Given this list of marker genes SLC7A5, SLC32A1, SLC1A2, SLC36A4 (solute carrier family 36 member 4), SLC36A2, SLC5A5, SLC7A3, SLC9A7, CALM1 (NCBI Gene Id 801), SLC9A2, SLC6A20, SLC34A1, SLC17A6, SLC17A8, SLC8B1, SLC43A1, SLC4A10, SLC25A22, SLC26A2, SLC12A2, SLC15A3, SLC26A9 (solute carrier family 26 member 9), SLC4A3, SLC1A3, CTNS, SLC25A26, SLC43A2, SLC38A2, SLC1A6, SLC1A5, SLC38A1, SLC12A7, SLC38A3, SLC4A2, SLC26A4, SLC3A1, SLC4A5, SLC6A15, SLC26A11, SLC4A9, SLC1A7, SLC1A4, SLC9A6 (NCBI Gene Id 53362), SLC26A6, SLC17A5 (solute carrier family 17 member 5), SLC7A2, SLC4A1, SLC24A2, SLC1A1, SLC15A1, SLC24A1, SLC7A7, SLC6A14, SLC4A8, SLC9A1, SLC5A12, SLC7A8, SLC25A18, SLC25A10, SLC12A6, SLC7A1, SLC34A2, SLC4A4, SLC8A2 (NCBI Gene Id 6543), SLC3A2, SLC24A5, SLC38A4, SLC9A4, SLC12A1, SLC8A3, SLC38A5, SLC25A11, SLC7A9, SLC8A1, SLC6A18 (solute carrier family 6 member 18), SLC17A1, SLC7A10, SLC25A1, SLC16A10, SLC9A5, SLC26A3, SLC34A3, SLC12A3, SLC4A7, SLC12A5 (NCBI Gene Id 57468), SLC20A1, SLC26A1, SLC24A3, SLC6A6, SRI, SLC26A7, SLC7A6, SLC9A8, SLC20A2, SLC17A7, SLC25A29, SLC6A12, SLC36A1, SLC9A9 (NCBI Gene Id 339579), SLC7A11, SLC6A19, AHCYL2, SLC24A4, SLC12A4 (solute carrier family 12 member 4), SLC5A8, SLC15A4, SLC9A3, here is a description of the gene set: Transport of inorganic cations/anions and amino acids/oligopeptides species: Homo sapiens Human Gene Set: REACTOME_TRANSPORT_OF_INORGANIC_CATIONS_ANIONS_AND_AMINO_ACIDS_OLIGOPEPTIDES